Given this list of marker genes Abcg8, Wdr89, Ippk, Ddb1 (NCBI Gene Id 13194), Bmpr2, Gk, Lancl2, Dmtf1, Kmt2d, Zfp955b, Tbc1d20, Zc3h18, Arb2a, Sgpp1, Tns3, Wdr44, Ddr2, B3galt1, Igsf6, Ago2, Aph1b, Ugt2b35, Katnbl1, Plcg1, Scn2a, Nr3c1, Wtap, Ppp3r1, Nol4l, Mboat7, Tubb6, Slc38a2, Thsd4, Pou2af2, Gpc6 (glypican 6), Jam3, Ehmt1, Agbl3, Gimap1, Nlrp6, Pate2 (prostate and testis expressed 2), Fam174a, Large1, Fndc5, Pik3r1, Col24a1, Ccdc7a, Pxdn, Pja2, Ppfia1, Rb1, Supt7l (NCBI Gene Id 77725), Mest, Cdk14, Adam3 (ADAM metallopeptidase domain 3), Cartpt, Gm14137, Ankhd1, Mbtd1, Nbea, Mcfd2, Pcsk2, Cry1, Pik3c2b, Cd4, Ppm1e, Ddhd1, Wdfy3, Tnpo1, Nf1, Dgki, 1700011L22Rik, Atp6v1e1 (ATPase, H+ transporting, lysosomal V1 subunit E1), Capza2, Sft2d3, Efr3a, Prkar2a, Grik2, Sh3pxd2b, Slc25a42, Slc4a8, Prr14l, Mrps25, Map1a (microtubule-associated protein 1 A), Sorbs1, Zfyve26, Cdk16, Zfp644, Insyn2b (inhibitory synaptic factor family member 2B), Hapln1, here is a description of the gene set: studied in species Mus musculus Mouse Gene Set: MIR_7091_3P Genes predicted to be targets of miRBase v22 microRNA mmu_miR_7091_3p in miRDB v6.0 with MirTarget v4 prediction scores > 80 (high confidence targets). from publication Chen Y, Wang X (PMID 31504780)